The following is a description of a gene set: studied in species Homo sapiens Hypertonic dehydration Human Gene Set: HP_HYPERTONIC_DEHYDRATION, and this is the list of marker genes: CA12, AQP2, AVPR2, SPINK5, KRT10, SLC5A1